Given this list of marker genes NSD1, COL13A1, MYOD1, SLC25A1, MYO9A, CHAT, VAMP1, SLC18A3, CCNK, SYT2, SNAP25, SLC5A7, AGRN, here is a description of the gene set: studied in species Homo sapiens Narrow jaw Human Gene Set: HP_NARROW_JAW Bigonial distance (lower facial width) more than 2 standard deviations below the mean (objective); or an apparently decreased width of the lower jaw (mandible) when viewed from the front (subjective).